The following is a description of a gene set: species: Mus musculus Mouse Gene Set: GOMF_MICROFILAMENT_MOTOR_ACTIVITY A motor activity that generates movement along a microfilament, driven by ATP hydrolysis., and this is the list of marker genes: Myo1g, Myh7, Myo9a, Myh6, Myh7b, Myo5b, Myh14, Myh13, Myo19, Myo5c, Myo1d, Myo10 (NCBI Gene Id 52514), Myh9, Myo1a, Myo1c, Myh8, Myo3a, Myo9b, Myh10, Myo1f, Myh11, Myh4, Myo15a, Myo1e, Actc1, Myh2, Myo1h, Myh1, Tnnt2, Myo6, Myl6, Myo3b, Myo7a, Myo7b, Myh15 (NCBI Gene Id 677358), Myh3, Myo5a, Myo1b